Given this list of marker genes PLAA, GORAB, LMX1B, RPS6KA3, PRR12, SP7, SMS, IFITM5, MED12, COL1A2, ASAH1, BRAF, FGD1 (NCBI Gene Id 2245), PIGG, GNB2, FBN1, KCNH1, NFASC, PKDCC (protein kinase domain containing, cytoplasmic), HRAS, OTUD6B, TMCO1, HDAC4, PTDSS1, ZFX, COL5A1, here is a description of the gene set: The ability of the finger joints to move beyond their normal range of motion. Human Gene Set: HP_HYPEREXTENSIBILITY_OF_THE_FINGER_JOINTS Hyperextensibility of the finger joints species: Homo sapiens